The following is a description of a gene set: Human Gene Set: HP_ABNORMAL_URETER_PHYSIOLOGY Abnormal ureter physiology A functional abnormality of the ureter. The ureter is the duct by which urine passes from the kidney to the bladder. studied in species Homo sapiens, and this is the list of marker genes: KANSL1, GRHPR, GTF2IRD1, HSPA9, NRIP1, SALL1, PAK2, UBE2A, CEP152, CREBBP, DVL3, NCAPG2, PTPN22, GATA3, TMEM270, HIRA, SIX5, TP63, CHD4, SDHB, WNT7B, PIGL, METTL5, ARVCF, ANKLE2, DNMT3A, CCNQ, NODAL, RFC2, YY1, POR, BBS2, SALL4, PIGA, CHD7, TRPS1, UMOD, SEMA3E, LZTFL1, NIPBL, ERI1, MYOD1, PAX6, IFT27, CDKN1C, MAPKBP1, FGFR2, ZEB2, ARNT2, CEP19 (centrosomal protein 19), STRA6, ATRX, NCF1 (neutrophil cytosolic factor 1), HLA-DPA1, NCAPD3, SIX1, FUZ, MNX1, DNAJC30, STAMBP, BPTF, COL18A1, BRF1, OTUD5, JMJD1C, SH2B1, BBS12, FBLN5, KMT2C, LAMC2 (laminin subunit gamma 2), ISL1, MYCN, CFAP418, LIMK1, BBS1, TRAPPC14, HNF1B, RARB, EHMT1, CHRM3, NKX2-1, UNC45A, SMC3, DACT1, GP1BB, MBTPS2, PIGQ, CDC45, SDHAF1, SARS1, RBM8A, STIL, CEP290, TRRAP, CIT, ATP7A, ROBO2, SDHA, SASS6, COPB2, NFIA, MFSD2A, ZMIZ1, EIF4H, SLC35A2, NUP37, WDR62, DCDC2 (NCBI Gene Id 606719), METTL27, PBX1, RREB1, KAT5, LAMB3, NPHP1, ZMYM2, KIF14, BAZ1B, MCPH1, BRD4, CEP63, CDK5RAP2, TAF6, CTLA4, HNRNPU, TNXB, IFT172, CCBE1, ASPM, EXT1, SHANK3, TTI1, JAG1, HNRNPK, EBF3, PAX2, TRIM32, TTC8, CHRNA3, EP300, SDCCAG8, TBX1, PIGT (phosphatidylinositol glycan anchor biosynthesis class T), WDPCP, PPP3CA, PUF60, MED12 (mediator complex subunit 12), CEP135, HLA-DPB1, PRMT7, LAMA3, PIGN, GNB1, MAP3K7, MKKS, BICC1, IGF2, PLXNA1, APC2, MAPKAPK5, UFD1 (NCBI Gene Id 7353), BUD23 (BUD23 rRNA methyltransferase and ribosome maturation factor), BBS5, TRAPPC10, ELN, SOX17, RAP1B, HOXA13, RECQL4, EYA1, DDX6, AFF4, VANGL1, PRTN3, COMT, KCNQ1, FGF10, LTBP1 (NCBI Gene Id 4052), SDHD, HAAO, BBS7, ZMYM3, DSTYK, KCNQ1OT1, SMC1A, PHC1, SPOP, EFEMP2, MID1, KIFBP (NCBI Gene Id 96724), SCAPER, HPSE2, SLC26A1, BBIP1, PSMD12, BNC2, POLR3A, CDH11, GTF2IRD2, CENPE, STX1A, CDK6, BBS9, IFT74 (NCBI Gene Id 80173), KMT2D, ASXL1, RAD21, WARS1, FGFR3, BBS4, BBS10 (Bardet-Biedl syndrome 10), MCM7, VPS37D, MKS1, FKBP6, HDAC8, GTF2I, RPL11, SEC24C, SCLT1, CLIP2, FLNA, UFC1, KNL1, DHCR7, RALGAPA1, SETBP1, FANCI, TBL2, ARL6, TBX18, MLXIPL, GREB1L, LRIG2, PIGO, FANCF, PYCR2, SF3B2, NSD1, KDM6A, RERE, RBCK1, ACTG2, TAF13, H4C9 (H4 clustered histone 9)